Given this list of marker genes Ces1d, Cyp4a12a, Cyp4a14, Cyp4a31, Cyp4a30b, Ces1b, Ces1h, Cyp4a29, Cyp4a10, Ces1c, Ces1f, Acad9, Abhd1, Ces1e, Acadm, Ces1g, Olah, Cyp4a32, Crot, Crat (carnitine acetyltransferase), Cyp4a12b, Abhd3, Oxsm, Ces1a, Acot7, Abhd2, here is a description of the gene set: studied in species Mus musculus The chemical reactions and pathways involving a medium-chain fatty acid. A medium-chain fatty acid has an aliphatic tail containing 6 to 12 carbons. Mouse Gene Set: GOBP_MEDIUM_CHAIN_FATTY_ACID_METABOLIC_PROCESS